The following is a description of a gene set: part of: SWI/SNF chromatin remodelers This event has been computationally inferred from an event that has been demonstrated in another species.<p>The inference is based on the homology mapping from PANTHER. Briefly, reactions for which all involved PhysicalEntities (in input, output and catalyst) have a mapped orthologue/paralogue (for complexes at least 75% of components must have a mapping) are inferred to the other species. electronically inferred by orthology from the curated human pathway Reactome Pathway: Formation of the embryonic stem cell BAF (esBAF) complex species: Mus musculus, and this is the list of marker genes: Arid1a, Smarcc2, Bcl7a, Ss18, Smarcd1, Bcl7b, Phf10, Smarcd2, Smarca4, Smarcc1, Smarcb1 (NCBI Gene Id 20587)